The following is a description of a gene set: part of: Fc epsilon receptor (FCERI) signaling electronically inferred by orthology from the curated human pathway species: Mus musculus This event has been computationally inferred from an event that has been demonstrated in another species.<p>The inference is based on the homology mapping from PANTHER. Briefly, reactions for which all involved PhysicalEntities (in input, output and catalyst) have a mapped orthologue/paralogue (for complexes at least 75% of components must have a mapping) are inferred to the other species. Reactome Pathway: FCERI mediated NF-kB activation, and this is the list of marker genes: Igll1, Psma6, Psmd1, Tab1, Ube2v1 (ubiquitin-conjugating enzyme E2 variant 1), Psmb4, Fcer1a, Psma4, Psmc1, Ube2n, Psma2, Psmb7, Psmc6, Ikbkb, Tab2, Psmd7, Psmb5 (proteasome (prosome, macropain) subunit, beta type 5), Nfkb1, Psmc5 (protease (prosome, macropain) 26S subunit, ATPase 5), Psma5, Ube2d1, Ubb (NCBI Gene Id 22187), Psma7, Psma1, Rps27a, Psmd13, Cdc34, Psma3, Rela, Malt1, Psmc3, Nfkbia, Psmd12, Psmc2, Psmc4, Tab3, Ms4a2, Cul1, Psmd6, Pdpk1, Psmb6 (proteasome (prosome, macropain) subunit, beta type 6)